Given this list of marker genes UBE2Q1, FCHO2, PCDHA7, GOLGA8A, ZNF233, AZIN1, KLF6, GALC, CD36, MPHOSPH8, ILRUN, FGF1, PMP2, PDIA6, ANK3, MAGEE1, PCDH7, C22orf39, GRID1, CDC14A, KATNBL1, MITD1, NR1D2, RUFY2, PISD, TMSB10, RLN1, TENM1, CREBRF, TNPO1, NFIX, CEP41, CNR1, C10orf88, P4HA3, HNRNPA3, RAI2, PEX5, ELAVL2, ARID4B, NSMCE4A, AUTS2, NXPH1, TRIB2, TENT2, HDAC4, WDR7, PPM1A, NAALAD2, ITM2A, ULBP1, PPARGC1A, RNF220, XG, CDYL, CTBP1, PLCL2, SP3, TMEM67, GDAP2, PIGK, RUNX2, MUC15, PCDHA4, OTUD4, PRRC2C, CACNA1B, SMPX, DNM1L, GPAM, ZC3H13, SAXO1, MZT1, CEP170, UBR3, FBN2, ALDH18A1, PCDH18, DCAF10, FAM76A, TPP2, GOLIM4, RCN2, CDH13, LEPR, ASAP2, CPED1, CCDC68, RAB21, ZNHIT6, KCNQ5, PCNP, SNAI2, KMT5A, PCDHA6, TTI2, NLK, NRG1 (neuregulin 1), DAGLA, WFDC6, APRG1, LIPT2-AS1 (NCBI Gene Id 374408), RAB38, ZBTB21, PPP4R4, PCDHA10, FOXN3, ADAMTS5, PCDHA1, MCU, RIOX1, FAM222B, TANC2, TBX15, ATP1B1, PCDHAC2, PCDHA13, FMO3, SLC49A4, NRF1, PUM2, PCDHA5, PROX1, ABHD17B, SLC40A1, HOOK3 (NCBI Gene Id 84376), AKAP1, PCDHAC1, PCDHA11, UNC80, ZNF454, FAM168A, ZNF749, ASXL1, ARL17A, HCN1, BCOR, DLC1, SMG1, CDK16, SPRED2 (NCBI Gene Id 200734), GLRX3, RALGAPB, SYPL1, HS3ST3B1, GTF3C3, GRIA4, GDA, TANC1, YPEL4, GOLGA6C, KBTBD8, GABRA4, STK35 (serine/threonine kinase 35), MYO1E, DYNLT5, TSHZ3, RYR2, ADCYAP1, ENY2, CEP192, PLA2G4A, POLR3GL, MTTP, GALNT1, WDR35, NAT8L, CDH15, KMT2C, CDH19, JAG1, PCDHA2, PDE10A, PDZD2, HACE1, NECTIN3, CAMSAP1, PCDHA12, CUL3, GRM6, LCORL (NCBI Gene Id 254251), PTPN2 (NCBI Gene Id 5771), RC3H1, PCDHA3, NWD2, TPH2, PI4K2A, GIGYF2, SLC26A3, PDCD6IP, ZNF124, EDNRA, RNF145, PEAK1, MEI4, DMXL2, SEMA3C (semaphorin 3C), ZFAND5 (zinc finger AN1-type containing 5), SIRT1, CD46, ARHGAP20, CDK14, MTM1, ARID1A, NRXN1, EFCAB5, TMEM184B, RORA, ZNF397, GNB1, PNN, RNF146 (ring finger protein 146), TPGS2, CCDC85A, LGALS8 (galectin 8), UGT8, STEAP2, SLC7A14, CKAP5, MGARP, FAM133B, ST6GAL2, DIAPH1, CTPS2, KIF21A, PPP3R1, DENND1B, DNAAF10, PCGF3, MAP2K1, BBS9, here is a description of the gene set: from publication Chen Y, Wang X (PMID 31504780) Human Gene Set: MIR539_3P studied in species Homo sapiens Genes predicted to be targets of miRBase v22 microRNA hsa-miR-539-3p in miRDB v6.0 with MirTarget v4 prediction scores > 80 (high confidence targets).